The following is a description of a gene set: Human Gene Set: MIR21_5P Genes predicted to be targets of miRBase v22 microRNA hsa-miR-21-5p in miRDB v6.0 with MirTarget v4 prediction scores > 80 (high confidence targets). from publication Chen Y, Wang X (PMID 31504780) species: Homo sapiens, and this is the list of marker genes: PPP1R3D, KDM7A, CHIC1, GID4, GPATCH2L, BAHD1, IL12A, EPHA4, CDH7, KDM1B, STK38L, PAN3 (poly(A) specific ribonuclease subunit PAN3), AKAP12, CCL1, EHD1, UBE2D1 (NCBI Gene Id 9335), SPRY1, CNOT6, KHDC1L, MSH2, KCNJ10, NIPAL2, PELI1, SCML2 (NCBI Gene Id 10389), NFIB, OLFM3, DUSP8, LPA, GATAD2B (GATA zinc finger domain containing 2B), CSRNP3, LTV1, FAM3C, PPP1R3A, VCL, ZNF367, SMARCD1, UBE2D3, JAG1, SPRY2, STAT3, CFAP300, KLHL15, LRRC57, SKI, SOX5, RMND5A, CPEB3, FAM13A, NTF3, USP15, RP2, TIMP3, PRDM11, SKP2, SYT15, CASKIN1, ZNF704, PDCD4 (programmed cell death 4), ALX4, PITX2, KRIT1, MALT1, BEST3, RECK, MPRIP, FGF18, MEI4, ZDHHC17, CLIC2, FASLG, HIPK3, RNF103, GLCCI1, ITCH, PLAG1, OSR1, RASA2, RASGRP1, DLGAP1, YAP1, ZBTB41, NFIA, LATS1, TGFBI, GABRB2, RBMS3, ANGPTL5, ADGRG2, WWP1, CLDN8, STAG2, RAB6D, C7, MATN2, THRB, PCSK6, NKIRAS1, MINDY2, ARHGAP24, SPEF2, MCMDC2, FRMD3, PLAA, NIPAL1, RALGPS2, KLF3 (KLF transcription factor 3), BCL7A, HSD17B4 (NCBI Gene Id 3295), YOD1, SMAD7, NPPB (natriuretic peptide B), UBR3, PLEKHA1, RSAD2, MAP3K1, TENT5A, KBTBD6, TMEM170A, CREBRF, RBPJ, MED21, PBRM1, MBNL3, FDX1, GLIS2 (NCBI Gene Id 84662), RASA1, PPP1R3B, CUX1, KHDC1, ARL1, STK40 (NCBI Gene Id 83931), RAD51AP1, SLC30A10, ATXN10, NEGR1, GRAMD2B, PDZD2, TPRG1L, ELF2, BCL11B, SOS2, PTPN20, MAST4, BCL11A, CCL20, BTG2, ANKS1B, EPM2A, TIAM1